Given this list of marker genes SLC22A12, here is a description of the gene set: part of: SLC transporter disorders Reactome Pathway: Defective SLC22A12 causes renal hypouricemia 1 (RHUC1) species: Homo sapiens Urate is a naturally occurring product of purine metabolism and is a scavenger of biological oxidants. Uric acid readily precipitates out of aqueous solutions causing gout and kidney stones. Due to this ability, changes in urate levels are implicated in numerous disease processes. The human gene SLC22A12 encodes urate transporter 1 (URAT1), predominantly expressed in the kidney and is involved in the regulation of blood urate levels. This transport can be trans-stimulated by organic anions such as L-lactate (LACT). Defects in SLC22A12 result in idiopathic renal hypouricaemia 1 (RHUC1; MIM:220150), a disorder characterised by impaired urate reabsorption at the apical membrane of proximal renal tubule cells and high urinary urate excretion.